Given this list of marker genes TBX1, UNC45A, CACNA1D, WNK4, GNB2, SLC33A1, SLC34A3, HSD3B2, EIF4H, PPOX, TMEM270, AIP, SCN10A, GABRA3, DSG1, CA2, UNC93B1, TXNRD2, VHL, EGF, SLC34A1, SDHC, SAMD9, TRIM28, KCNE1, CAV1, NOS1AP, APC2, ADAMTS3, SOX5, MT-CO3, GTF2IRD2, H19, DBH, BMP2, SDHB, KCNJ2, PTH1R, HFE, NR0B1, ZNRF3, BTNL2, ASL, BRCA2, BCS1L, KCNJ5, TRIO, CYP3A4, PIGT, AQP2, HLA-DQB1, CDKN2A, SLC11A2, HIRA, GCSH, PDGFRB, AFG2A, TNFRSF11B, CACNA1C, SCN4B, CRELD1, FAT4, ALK, CDKN1B, CALM1, NAB2, CDKN2B, AIRE, SLC30A10, PCBD1, SCNN1G, PHEX, INVS, NFKB2, ALG12, ATP6V0A2, SDHD, CYP24A1, MMP1, HNF4A (hepatocyte nuclear factor 4 alpha), CLCNKB, FGFR1, CTNS, CLCN5, SEC24C, EPAS1, CYP11B1, ELP1, ARVCF, RMRP, NR3C2, GATA3, TRDN, WNK1, ATP6AP1, CNNM2, ZEB2, SLC30A9, OCRL, AP2S1, ORAI1, HLA-DRB1, BRAF, CCDC134, SCNN1B, AKAP9, HSD11B2, TNFRSF11A, IL36RN, OBSCN, PBX1, COMT, FAH, NUP214, OSTM1, MRAP, CYP2R1, SLC30A2, VDR, SLC2A2, PIEZO1, STEAP3, ATP1A1, HMGCS2, SMAD4, PKLR, AVPR2, BMP6, NDUFB8, ADCY10, IFT122, KRAS, SETD2, SCNN1A, RREB1, TDP2, KCNN4, RFX7, BSND (barttin CLCNK type accessory subunit beta), MC2R, RAF1, FARSB, TBX5, COL7A1, ABCC6, INPPL1, CTNNB1, PRKAR1A, SLC3A1 (NCBI Gene Id 6519), PLEKHM1, FOCAD, BCL6, EHHADH, RACGAP1, SLC9A3, PTH, GNAS, STX1A, GTF2IRD1, BAZ1B, TMEM127, ANK2, TBCE, POR, RYR1, TSFM, PAX2, GEMIN4, LAMB3, PKD2, SLC4A1, FOXP1, STAT6, CA12, IVD, AP1B1, HADHA, VPS37D, NDUFAF6, MIR140, METTL27 (NCBI Gene Id 155368), CA5A, DGCR6, NR3C1, PREPL, NHERF1, TRPS1, KCNJ18, SNTA1, PRF1, ACADVL, CMPK2, DGCR2, CCND1, BMPR1A, ATP7B, CYP11A1, HMBS, CLDN10, FXYD2, TMEM38B, FAM20C, UBR1, STAB1, DIS3L2, AP1S3, CHD7, HBB, USP53, TRAF3, CLCNKA, FTL, BCL2, TIAM1 (TIAM Rac1 associated GEF 1), SLC20A2, SLC26A1, SYK, GATM (glycine amidinotransferase), FKBP6, CLDN19, SLC5A1, GTF2I, KCNJ1, KLHL3, MT-CO1, ANKH, RFC2, LIMK1, SLC12A1 (NCBI Gene Id 6557), RRAGD, ETHE1, GCM2, SKIC2, NF1, USP8, SCN4A, CLDN16, MAX, CDKN1C, CASR, TNFSF11, GP1BB, KIF1B, CLIP2, PLVAP, TP53, DZIP1L, CAMKMT, WT1, LPIN1, COL4A3, CLCN7, CACNA1S, GPC3, REST, LDHA, SLC4A2, POLRMT (NCBI Gene Id 5442), PDGFB, ALDOA, KIF23, POLG2, CSF1R, CDKN2C (NCBI Gene Id 654235), SCO2, COG2, SEC61A1 (SEC61 translocon subunit alpha 1), DGCR8, NCF1, ALG8, SLC34A2, TERT, INSR, TBX19, CDH23, ALAS2, KCNQ1, ARNT2, CYP17A1, TRPM6, SLC2A1, CDKN1A, TLR3, ABCB6, TCIRG1, ZFX (NCBI Gene Id 7543), SLC7A7, SLC39A8, MAGED2, CUL3, CDC73, SLC39A4, CYP11B2, MDH2, PPM1B, CARD9, FAM111A, NRAS, AP1S1, SNX10, ENPP1, TMEM199, CAV3, POU6F2, CYP27B1, FOXN1, LAMA3, SLC12A3, BTK, NNT, SERPINA6, PIK3C2A, SCN5A, FTH1, GNA11, COL3A1 (collagen type III alpha 1 chain), NOTCH3, BUD23, KCNE2, TRNT1, EIF2AK3, SKIC3, HLA-DQA1, TICAM1, SLC25A38, FOXP3, GALNT3, HADHB, PSTPIP1, SDHA, TMPRSS6, HAMP, FGF23, KL, KCNJ10, LYST, KCNE3, TFR2, RET, DNAJC30, STX16, ESS2, SLC4A4, JMJD1C, ATIC, CALM2 (NCBI Gene Id 805), STAR, HRAS, LAMC2, CPOX, KCNH2, HJV, SDHAF2, CLCN2, NSD1, CCBE1, TBK1, ALDOB, SLC26A3, SLC25A11, ATP7A, DMP1, ALAD, ELN, MLXIPL (MLX interacting protein like), PIGA (NCBI Gene Id 5277), TBL2, SLC40A1, SARS2, ALPL, DLST, PKHD1, UFD1, IRF4, CALM3, IARS1, ATP6V0A4, SLC31A1, FH (fumarate hydratase), ABCD3, GNAS-AS1, DEF6, SLC39A14, TRIP13, DNMT3A, CP (NCBI Gene Id 1356), MEN1, here is a description of the gene set: Human Gene Set: HP_ABNORMAL_BLOOD_ION_CONCENTRATION Abnormal blood ion concentration Abnormality of the homeostasis (concentration) of a monoatomic ion. species: Homo sapiens